The following is a description of a gene set: Genes up-regulated in skin: uninfected versus S. aureus infection. Neutrophil abscess formation is critical in innate immunity against many pathogens. Here, the mechanism of neutrophil abscess formation was investigated using a mouse model of Staphylococcus aureus cutaneous infection. Gene expression analysis of S. aureus-infected skin revealed that induction of neutrophil recruitment genes was largely dependent upon IL-1beta/IL-1R activation. Unexpectedly, using IL 1beta reporter mice, neutrophils were identified as the primary source of IL-1beta at the site of infection. Furthermore, IL-1beta-producing neutrophils were necessary and sufficient for abscess formation and bacterial clearance. S. aureus-induced IL 1beta production by neutrophils required TLR2, NOD2, FPRs and the ASC/NLRP3 inflammasome. Taken together, IL-1beta and neutrophil abscess formation during an infection are functionally, spatially and temporally linked as a consequence of direct IL-1beta production by neutrophils. from publication Cho JS, Guo Y, Ramos RI, Hebroni F, Plaisier SB, Xuan C, Granick JL, Matsushima H, Takashima A, Iwakura Y, Cheung AL, Cheng G, Lee DJ, Simon SI, Miller LS (PMID 23209417) Human Gene Set: GSE36826_NORMAL_VS_STAPH_AUREUS_INF_SKIN_UP studied in species Homo sapiens, and this is the list of marker genes: HGS, BUB3, HCP5, LAMP3, ORMDL2, RPS11, CLPB, YKT6, BBS7, BPY2, TFE3 (NCBI Gene Id 8244), H2AC6, LRP8, SPEN, H2BC9, COX7A2, DDX39A, AARS1, ZNF142, IDO1, IL18R1, HMGN4, REV3L, SLC3A2, PARK7, CD101, PITPNA, IDS, DIAPH1, PEX13, BACH1, FLNA (NCBI Gene Id 8272), ARAP3, KCNN4, MYCL, PPP4C (protein phosphatase 4 catalytic subunit), ACVR2A, NAMPT, HNRNPR, ILF2, MIR22HG, TJAP1, ZNF207, PSME3, PID1, C5AR2, TCF20, PTP4A2, PSMA5, FILIP1L, AQP9, JUND, CD58, GRIK1, CXCL8, ST14, RAB5IF, A4GALT, SHC1, CHCHD2, ADSS2, SNRPB, PSMC3, HMGCR, MAP4K4, SLC7A11, ZBTB44, TRAF1 (TNF receptor associated factor 1), PSMD1, SLC16A6, CST6, BPNT2, SMAD3, LAD1, BID, NCBP1, RBM14, THBS1, FPR3, ABHD2, CDK2AP2, U2AF2, ACOT9, PACSIN2, CYTIP, PSMA3, RNF41, LTA4H, YIF1A, KCNJ15, GPR153, FHL3, DNAJB5, S100A9, GDI1, ANXA5, TTLL4, HNRNPA2B1, HCLS1, TPMT, PDE4D, LFNG, CD53, GLIPR1, STK38L, RPL8, ALCAM, SLC35B1 (solute carrier family 35 member B1), TXNRD1, MAMLD1, ANG, ATP1A1, TYMP, CYB5R3, HNRNPM, PLAC8, DERL1, GMIP, UBIAD1, KLRC3, UNC119B (unc-119 lipid binding chaperone B), USP3, TCTN3, PUF60, DUSP6, TES, TMEM43, RNPS1, ST3GAL6, LBR, NSD3, S100P, TMEM158, HNRNPK, PGD, PDLIM7, RHOG, PIGL, OLR1, ISG20, EOLA1, DDX17, ERO1B, EIF6, ENY2, ADGRE2, TREM1, DGKD, APOBR, UBE2A, CST7, SRPRB, IFNGR1, FCN1, RPA2, GNG11, PABPN1, CRLF2, LPXN, PNP, TCIRG1, PSMA1, IKBKG, CD5, C15orf39, FOS, KYNU, GAPDH (NCBI Gene Id 2597), PFN1, CCR7, FPR1, MTF1, SORL1 (NCBI Gene Id 6653), FUBP1, CORO1A, FRY, ITGAE, PPP1CB, PRKCH, DUS2, SQLE, CHTOP, BTG1, SRSF2, TBC1D13, YARS1, SLC25A37, TMEM214, CLDND1, NME1, HNRNPA3, SRC, BIRC3, MSC, VEGFA, ELMO3, CASP1, MOB1A